The following is a description of a gene set: Human Gene Set: GOBP_REGULATION_OF_POLYSACCHARIDE_METABOLIC_PROCESS Any process that modulates the frequency, rate or extent of the chemical reactions and pathways involving polysaccharides. studied in species Homo sapiens, and this is the list of marker genes: PPP1R3B, GCK, AP2A1, MIR1271, MIR15B, PPP1R3G, IGF1 (insulin like growth factor 1), IRS2, IRS1, NFKB1, INPP5K, EGF, PPP1R3E, PPP1R3C, PASK, HAS2, PHKA1, ADCY10, ENPP1, AKT1, MIR195, AKT2, DYRK2, PPP1R3A, SELENOS, SORBS1, PDGFB, PHLDA2 (pleckstrin homology like domain family A member 2), EPM2AIP1, KHK, SMPD3, CLTC, GSK3B, GCGR, INSR, INS, POMC (proopiomelanocortin), PRKAG3, HMGB1, RUBCNL, GRB10, TGFB1, PPP1R3F, PPP1CA, IGF2, PPP1R3D, GSK3A, PTH, PHKG2